Given this list of marker genes SAYSD1, CYSLTR2, SEMG1, KLF9, CLC, SMPD3, ALOX15, SIGLEC8, ADORA3, PTGDR2, CD52, SLC29A1, MIAT, NCR1, C12orf60, DDB2, INSYN2B, DOK2, PRSS33, NPIPB3, here is a description of the gene set: studied in species Homo sapiens Systems biology is an approach to comprehensively study complex interactions within a biological system. Most published systems vaccinology studies have utilized whole blood or peripheral blood mononuclear cells (PBMC) to monitor the immune response after vaccination. Because human blood is comprised of multiple hematopoietic cell types, the potential for masking responses of under-represented cell populations is increased when analyzing whole blood or PBMC. To investigate the contribution of individual cell types to the immune response after vaccination, we established a rapid and efficient method to purify human T and B cells, natural killer (NK) cells, myeloid dendritic cells (mDC), monocytes, and neutrophils from fresh venous blood. Purified cells were fractionated and processed in a single day. RNA-Seq and quantitative shotgun proteomics were performed to determine expression profiles for each cell type prior to and after inactivated seasonal influenza vaccination. Our results show that transcriptomic and proteomic profiles generated from purified immune cells differ significantly from PBMC. Differential expression analysis for each immune cell type also shows unique transcriptomic and proteomic expression profiles as well as changing biological networks at early time points after vaccination. This cell type-specific information provides a more comprehensive approach to monitor vaccine responses. Genes up-regulated in neutrophil 7d vs 0d in adults after exposure to 2011-2012 trivalent inactivated vaccine (A/California/7/09 (H1N1), A/Perth /16/2009 (H3N2), B/Brisbane/60/2008), time point 7D. Comment: Up-regulated DE RNA transcripts (up >= 1.5x) shared between both TIV-vaccinated donors Human Gene Set: HOEK_NEUTROPHIL_2011_2012_TIV_ADULT_7DY_UP from publication Hoek KL, Samir P, Howard LM, Niu X, Prasad N, Galassie A, Liu Q, Allos TM, Floyd KA, Guo Y, Shyr Y, Levy SE, Joyce S, Edwards KM, Link AJ (PMID 25706537)